Given this list of marker genes HOXA13, VPS35L, FGFR2, EP300, FGFR1, here is a description of the gene set: Short first metatarsal bone. studied in species Homo sapiens Short first metatarsal Human Gene Set: HP_SHORT_FIRST_METATARSAL